Given this list of marker genes BNC2, THAP12, GPR21, PAX1, TLE4, PHOX2B, PCTP, ATXN7L1, LEAP2, DAB1, DIS3L, ESR1, MMP3, ITM2C, KLF12, DCHS2, NFE2L2, RBMX, ELF4, TFAP4, SESN2, GRIN2B, MEIS1, KLF14, HOXA3, CDK2AP1, DYNC1I2, BCL6 (NCBI Gene Id 604), OTX2, ATP1B1, C11orf87 (NCBI Gene Id 399947), GTF2E2, SSBP3, KCNJ13, NNAT, GPRIN3, SPAG9, SOX4, IGF2BP1, MAN2A2, GATA3, ZW10, NRAS, SNX25, DRD3, FTHL17, SEMA6C, PIK3R3, CALM1, FAM78A, LINC00314, HOXB2, OMG, PRP4K, PRIMA1, GPC6, PPFIA2, DPYSL5, TLX3, SFRP2, SKP2, PPARGC1A, EFNA5, GPC3, ZNF827 (zinc finger protein 827), GLRA2, MRPL24, SLMAP, SAMD12, FGF7, LRRC3B, CDC42EP3, NCBP3, MBNL1, MEF2C, ANK2, PDGFRB, NTN1, RSPO2, ZFPM1, NEK6, DSCAM, MID1, PPP1R10, ANK3, ATOH7, MRAP, ATP2B4, GRHL3, CNTFR, CEPT1, SHC3, ELAVL4, DMD, MAP3K4, AFF4, OLIG2, RORA, TLK1, CITED2, INHBA, HOXA2, SNCAIP, MPZL3, HOXC4, TBC1D8B, PRDM16, PPP2R2A, DTX3L, MAML3, TRAM1, GANAB, HHEX, TRPM3, FBXW7, DLG2, DNAJB5, POU4F1, PPP3CC, TSC22D4, SPARCL1, SOX5, FZD7, LSAMP, DSTN, KANK1, JADE2, DUSP1, CDH13, HEPACAM, SGCD (NCBI Gene Id 6444), BCL11A, DCAF11 (DDB1 and CUL4 associated factor 11), LUC7L3, PAX6, NTRK3, CACNG3, NR2F2, LRRN1, PATZ1, SIX5, ZHX3, RAB10, APP, THBS2, EPHB2, MYCL, EBF1, SORT1, S100PBP (S100P binding protein), SATB2, TGIF1, PCSK1, KRTAP8-1, SKIL, HOXB6, MRPS18B, SOX13, MYLK, FOXP2, STEAP2, ZNF462, DSEL, TFDP2, FGFR2, OLFM1, MLLT6, CDC42EP5, EPHA7, MAPK3, ADHFE1, FOXP1, CD14, EGFLAM, ACTB, ASPA, LIPG, FN1 (NCBI Gene Id 2335), PHTF1, DLGAP4, PARP9, SALL3, LOX, FOXN3, LOXL4, MGLL, EIF4EBP2, CHD2, CACNA1D, MYH2, CNMD, NEUROG1, POU2F1, RRS1, DDIT3, here is a description of the gene set: Genes having at least one occurrence of the highly conserved motif M144 AAANWWTGC in the regions spanning 4 kb centered on their transcription starting sites. The motif does not match any known transcription factor binding site. from publication Xie X, Lu J, Kulbokas EJ, Golub TR, Mootha V, Lindblad-Toh K, Lander ES, Kellis M (PMID 15735639) Comprehensive identification of all functional elements encoded in the human genome is a fundamental need in biomedical research. Here, we present a comparative analysis of the human, mouse, rat and dog genomes to create a systematic catalogue of common regulatory motifs in promoters and 3' untranslated regions (3' UTRs). The promoter analysis yields 174 candidate motifs, including most previously known transcription-factor binding sites and 105 new motifs. The 3'-UTR analysis yields 106 motifs likely to be involved in post-transcriptional regulation. Nearly one-half are associated with microRNAs (miRNAs), leading to the discovery of many new miRNA genes and their likely target genes. Our results suggest that previous estimates of the number of human miRNA genes were low, and that miRNAs regulate at least 20% of human genes. The overall results provide a systematic view of gene regulation in the human, which will be refined as additional mammalian genomes become available. studied in species Homo sapiens Human Gene Set: AAANWWTGC_UNKNOWN